The following is a description of a gene set: Human Gene Set: GOBP_CHROMOSOME_ORGANIZATION_INVOLVED_IN_MEIOTIC_CELL_CYCLE A process of chromosome organization that is involved in a meiotic cell cycle. species: Homo sapiens, and this is the list of marker genes: NCAPD2 (non-SMC condensin I complex subunit D2), SYCP1, TRIP13, MSH5, SHOC1, BAG6, AGO4, KASH5, C14orf39, CCNE2, ANKRD31, MAJIN, SIRT7 (NCBI Gene Id 51547), SPATA22, SMC2, SUN1, DMC1, EHMT2, SYCE3, NDC1, HORMAD1, P3H4, ATRX, TERB2, SYCE1, SYCE1L, RAD50, MLH1, BRIP1, RNF212B, NCAPH, IHO1, C1orf146, RNF212, CCNE1, ATM, CCNB1IP1, SPDYA, ZCWPW1, TERB1, STAG3, MAEL, MND1, TEX15, PSMC3IP, MEIOC, TERF1, TEX11, SMC4, REC8, MSH4, SPO11 (SPO11 initiator of meiotic double strand breaks), UBE2B, MEIOB, SYCP2, PRDM9, SYCE2, NCAPD3, MRE11, NCAPH2, MLH3, TEX12, MCMDC2, MEI4, FANCD2, RAD51